The following is a description of a gene set: Mouse Gene Set: GOMF_TRANSPORTER_ACTIVATOR_ACTIVITY Binds to and increases the activity of a transporter. species: Mus musculus, and this is the list of marker genes: Lrrc38, Atp1b3, Smdt1, Lrrc26, Akt1 (thymoma viral proto-oncogene 1), Lrrc52, Lrg1 (NCBI Gene Id 76905), Atp6ap1, Atp1b1, Stim1, Atp1b2, Nherf1, Pdzd11, Lrrc55